The following is a description of a gene set: Human Gene Set: REACTOME_SYNTHESIS_OF_GLYCOSYLPHOSPHATIDYLINOSITOL_GPI Synthesis of glycosylphosphatidylinositol (GPI) studied in species Homo sapiens, and this is the list of marker genes: PIGN, PIGW, PIGF, PIGP, PIGG, PIGX, PIGL, PIGC, PIGB, DPM2, PIGQ, PIGA, PIGV, PIGO, PIGH, PIGZ, PIGM, PIGY